Given this list of marker genes RASGRP2, DGKK, DGKQ, DGKA, DAGLA, DGKH, PRKCH (protein kinase C eta), ABHD12, PRKCQ, DGKG (NCBI Gene Id 1608), ABHD6, ITPR1, ITPR3 (NCBI Gene Id 3710), DGKI, TRPC6, PRKCD, DGKD, DAGLB (diacylglycerol lipase beta), RASGRP1, TRPC3, DGKZ, ITPR2, DGKE, DGKB, PRKCE, TRPC7 (NCBI Gene Id 57113), MGLL, here is a description of the gene set: studied in species Homo sapiens part of: G alpha (q) signalling events; Platelet activation, signaling and aggregation Hydrolysis of phosphatidyl inositol-bisphosphate (PIP2) by phospholipase C (PLC) produces diacylglycerol (DAG) and inositol triphosphate (IP3). Both are potent second messengers. IP3 diffuses into the cytosol, but as DAG is a hydrophobic lipid it remains within the plasma membrane. IP3 stimulates the release of calcium ions from the smooth endoplasmic reticulum, while DAG activates the conventional and unconventional protein kinase C (PKC) isoforms, facilitating the translocation of PKC from the cytosol to the plasma membrane. The effects of DAG are mimicked by tumor-promoting phorbol esters. DAG is also a precursor for the biosynthesis of prostaglandins, the endocannabinoid 2-arachidonoylglycerol and an activator of a subfamily of TRP-C (Transient Receptor Potential Canonical) cation channels 3, 6, and 7. Reactome Pathway: Effects of PIP2 hydrolysis